Given this list of marker genes SCN10A, HSPA14 (NCBI Gene Id 51182), HOXC13, FAM167A-AS1, DNAJC7, ST6GALNAC2, MOB4 (NCBI Gene Id 96815), NR0B1, FANCD2OS, TECTB, RAB3A, PIP5K1C, NSUN4, CENPF, TRAPPC9, CLDN16, MTNR1B, CTPS2, CFHR5, GHRHR, STK31, CEP43 (NCBI Gene Id 11116), ADAD1, SERTAD1, IRF7, PPDPFL, AEN, FLACC1, TP53RK, MDM2, HUS1, ITGA8, ZNF663P, H4C6, ATPAF1, RANBP3L, KLHL24, TARP, PRMT8, RNF183, LINC00943, TUSC2, FOXD1, PRL, VPS37B, SCEL, HIC1, TP53TG5, GAS8-AS1, SLX9, LINC00299, SPTB, PDE1A, KRT14, DUSP19, HYDIN2, ST8SIA3, NALF1, CCDC47, CPSF6, PALM3, CARTPT, NEK8, PIP5KL1, LALBA, POU5F1P4, MICU1, GAL3ST1, TRPC5OS, ZNF396, SSTR2, RASSF5, GOLGA1, CD7, ELF1, RELCH, SPINT3, IER5, DKFZP434A062, NUMB (NCBI Gene Id 94910), DBH-AS1, NEBL (nebulette), BBIP1, NOL4L, FANCB, SOX17, CTSE, BDNF, CYP1B1-AS1, SLC44A1, H1-9P, ANGPTL7, FOXL1, CMTM2, CLDN7, CDHR1, C18orf32, ENSG00000223438, LINC00905, BRAF, ZNF324, DYNLL2, FKBPL, LEPROTL1, NR5A1, ANXA2, DERL1, CSF3, ITCH, FLJ16779, F2R, DRD2, TRAF6, ZSCAN22, NACAD, JPH2, CSF2RA, HYAL4, CCN2, RABL3, FDXR, MARCHF6, GLB1L2, SERPINB3, GALNT15 (NCBI Gene Id 117248), TGIF2LY, KLRD1, BLOC1S2, SKIC2, AMER1, C7orf33, HYDIN, ADAM10, DDI1, RHBG, ASPDH, C1QTNF6, PLK1, CPSF7, SLC26A7, POLH, TTLL11, WDR72 (WD repeat domain 72), CETP, SV2A, ZNF586, LIMS3, PGK2, TM7SF3, METTL21C, H1-2, P4HA3, FBXL13, SMARCC2, TROAP, TSPAN6, SPP2, KRTAP3-1, LINC00028 (NCBI Gene Id 140875), NEDD8, CLIC5, PITPNM3, SHISA6 (shisa family member 6), ZNF513, IRX3, LINC01555, FLG, ZNF780B, BCAS4, ZP2, POLN, PLXDC2, PSMD12, FRAS1, SHISAL2A, HSF5, SLC44A4, RASSF9, ZNF346, NEUROD2, TPTE2P2, SLITRK4, NR6A1, ATG9B, CADPS, ELOC, SESN2, ITPKA, NECAB1, TNXB, NTN5, here is a description of the gene set: studied in species Homo sapiens from publication Szanto A, Balint BL, Nagy ZS, Barta E, Dezso B, Pap A, Szeles L, Poliska S, Oros M, Evans RM, Barak Y, Schwabe J, Nagy L (PMID 21093321) Human Gene Set: GSE16385_IFNG_TNF_VS_IL4_STIM_MACROPHAGE_DN Human CD14 positive monocytes were purified from healthy volunteers’ blood and cultured in vitro for 4, 12, 24, 72 hours. While culturing, macrophages were activated alternatively with interleukin-4 (IL-4 100 ng/ml) or classically with interferon-gamma (IFNg 100 ng/ml)+tumor necrosis factor (TNF 50 ng/ml) or left without activation. Simultaneously, macrophages were also treated with vehicle (DMSO:ethanol) or 1mM synthetic PPARg agonist, Rosiglitazone. We used Affymetrix microarrays (U133Plus 2.0) to analyze activation and PPARg-induced gene expression changes. Genes down-regulated in macrophages (12h): IFNG and TNF versus IL4.